The following is a description of a gene set: species: Homo sapiens Human Gene Set: HP_MULTIPLE_IMPACTED_TEETH Multiple impacted teeth The presence of multiple impacted teeth., and this is the list of marker genes: SH3BP2, FLNA, HOXD13, PTH1R, CDH11